Given this list of marker genes Pafah1b1, Cntrl (NCBI Gene Id 98835), Sox17, Thoc5, Ing2, Bmi1, Ncoa3, Ulk4, Fubp1, Myb, Etv5, Hoxb4, Evi2b, Ndufs6, Smyd5, Notch1, Fut10, Yme1l1, Vangl2, Tial1, Cdk2ap2, Tdrd12, Nap1l2, Mllt3, Ext1, Gnl3, Wwtr1, Stra8, Fut9, Thoc2, Sfrp2, Zbtb16, Cdkn2a, Samd9l, Wnt3a, Mpl, Cul3, Tgfb2, Prdm15, Nanog, Fzd7, Wnt7a, Zfp36l2, Lbh, Esrrb, Gm30731, here is a description of the gene set: studied in species Mus musculus Mouse Gene Set: GOBP_STEM_CELL_DIVISION The self-renewing division of a stem cell. A stem cell is an undifferentiated cell, in the embryo or adult, that can undergo unlimited division and give rise to one or several different cell types.